Given this list of marker genes CCNA2, FOXM1, MT1JP, AURKA, NSD2, DLGAP5, KIF11, RFC3, CKS1B, AURKB, CKS2, ZWINT, MKI67, CDK1, UBE2C, CENPF, SHCBP1, CENPE, TYMS, PCNA (proliferating cell nuclear antigen), ASPM, BUB1, CCNF, HMMR, MYBL2, CDCA8, CDC20, NUSAP1, KIF18B, ESPL1, PRC1, SMC2, H2AX, RRM1, RRM2, CCNB2, CDCA3, PRIM1, TMPO, BIRC5 (NCBI Gene Id 332), NDC80, here is a description of the gene set: Neighborhood of CENPE Neighborhood of CENPE centromere protein E, 312kDa in the GNF2 expression compendium Human Gene Set: GNF2_CENPE species: Homo sapiens